Given this list of marker genes HRH1, HIF1A, APP, DRD2, DDHD2, NPHP1, NPS, KMT2A, DRD1, PLN, RIC8A, CHRNB2, PDE8B, BRAF, FOXB1 (NCBI Gene Id 27023), ABCA7, TAFA2, HMGCR, TTC36, LRRN4, OPN4, COMT, DEAF1, CREB1, PIANP, PIAS1, NOG, SLC7A11, NDRG4, ATXN1, ATP1A2, MEIS2, B4GALT2, DRD3, SLC1A2, IFT20, SYNGAP1 (synaptic Ras GTPase activating protein 1), RAG1, RGS14, DBH, GRIN1, HOXA1, MECP2, ITGB1, TUBA1A, CDK5, NETO1, GNAT2, NPHP4, NF1, B3GAT1, ADAM2, GRIN2A, PPP1R1B, KIT, DYNLRB1, ABCC8, TANC1, CTNS, GNAT1, PDE1B, KRAS, here is a description of the gene set: Human Gene Set: GOBP_VISUAL_BEHAVIOR studied in species Homo sapiens The behavior of an organism in response to a visual stimulus.